The following is a description of a gene set: species: Mus musculus The appearance of interferon-alpha due to biosynthesis or secretion following a cellular stimulus, resulting in an increase in its intracellular or extracellular levels. Mouse Gene Set: GOBP_INTERFERON_ALPHA_PRODUCTION, and this is the list of marker genes: Tlr8, Trex1, Irf7, Ptpn22 (protein tyrosine phosphatase, non-receptor type 22 (lymphoid)), Hmgb1, Trim65, Mavs (mitochondrial antiviral signaling protein), Nlrc3, Flt3 (FMS-like tyrosine kinase 3), Dhx36, Tlr7, Ap3b1, Tlr9, Stat1, Gbp4, Tlr4, Mmp12, Ddx3x, Nmbr, Irf3, Nmi (NCBI Gene Id 64685), Chuk (NCBI Gene Id 12675), Nmb, Dhx9, Ptprs, Havcr2, Zc3hav1, D1Pas1, Ap3d1, Traf3ip3, Tlr3, Tbk1, Ifih1, Setd2, Hspd1 (heat shock protein 1 (chaperonin)), Rigi